The following is a description of a gene set: studied in species Homo sapiens Genes up-regulated in arthritic (KRN model) CD4 T cells: germ free versus specific pathogen free conditions. Human Gene Set: GSE22140_GERMFREE_VS_SPF_ARTHRITIC_MOUSE_CD4_TCELL_UP from publication Wu HJ, Ivanov II, Darce J, Hattori K, Shima T, Umesaki Y, Littman DR, Benoist C, Mathis D (PMID 20620945) A general defect of GF K/BxN T cell proliferation response toward antigen motivated us to look for the impairment in GF K/BxN T cells that might leads to the low Ab production and reduced disease phenotype seen in GF K/BxN mice. To find the difference between GF and SPF K/BxN T cells in a broad and non-biased fashion, we performed gene-expression profiling of these cells using microarrays., and this is the list of marker genes: USP9Y (NCBI Gene Id 8287), ATP6AP1, CR1, BID, OASL, IGF1, DEFA4, BLZF1, LETMD1 (LETM1 domain containing 1), HOMER2, TLR5, EIF2S1, EFEMP2, HNRNPAB, APOBEC3C, CTSK, RPS6KA2, HCG4B, CTSL, CSF3R, RAB40B, NBR2, F13A1, RPL15, ERGIC3, DNAAF11, GADD45B, FSCN1, POP1 (NCBI Gene Id 23044), DNAJB9, KITLG, EREG, RERE, UBAP2L, POM121L6P, PLAU, SQSTM1, XPO6, BLVRA, FCMR, PHYH (phytanoyl-CoA 2-hydroxylase), OAS1, TRIP10, IFITM2, CD59, SERPINB2, IBTK, CXCL11, MX1, IL7R, GTF2H3, CXCL1, OLFML2B, FARP1, NCK2, TNFSF10, MAT2A, SYNJ2, MAPK13, FOXF1, PML, FBLN5, IRF9, FUT4, GABPB1, CELSR1, HESX1, PLCB4, PLD3, MMP7, ZBTB39, BCAR3, PLEK, IFIT1, GCLM, NOP56, RAP2C, DEGS1, XAF1 (XIAP associated factor 1), MRC1, MYO7A, ITSN1, IKZF1, CCNE2, MYO1E, ITGA6, AKR1C3, MAP3K1, NQO1, HTRA1, ITGB5, IFIT2, PDXDC1, NUP50, IL6, LIG4, SCAMP1, NUCB2, RGL1, ZC3HAV1, ZNF101, TSPAN4, CCT2, NUP188, RAB35, VASP, ABCE1, BEST1 (NCBI Gene Id 7439), MTSS1, PPP3CA, PCSK6, HIP1, SNCB, DMXL1, SLC7A8, ADCY3, THBS1, CXCL6 (C-X-C motif chemokine ligand 6), SEC23IP (NCBI Gene Id 11196), RTCB, PPY, PIP, IFIT5, CPQ, HS3ST1, MTFR1, MPP1, KCNC4 (potassium voltage-gated channel subfamily C member 4), TCF12, RNFT2, IFIT3, SH3GL1, CCL18, ELK3, ST3GAL6, MX2, IFI44, CD99, ATP8B3, SAR1A, CCL20, PHLDB1, S1PR1, FN1, CCNC, RSAD2, ADH5, COL15A1, PLIN2, ARNT2, TRIM27, DHX30, ELL2, CLEC11A, TUBB4A, DNASE1L1, SNRNP35 (NCBI Gene Id 11066), OAS2, GPS2, TFPI, IRF1, IPO7, CXCL10, CD4, ORC3, GPNMB (NCBI Gene Id 10457), PPBP, EPHX1, TMF1, SELENOP, WDR1, IRF7, APLP2, HPCAL1, PIBF1, IFI44L, POU2F2 (POU class 2 homeobox 2), ISG15, TPM1, CEBPZ (NCBI Gene Id 10153), SRP72, NOP16, STX4, CAPN2, MAGED1, CARM1, NISCH, PUM3 (NCBI Gene Id 9933), NRP1, PIM2, CCL15, EZH2, CLIP2 (CAP-Gly domain containing linker protein 2), FERMT2, AIMP2, DNMBP, RAB5C, ADD1, TACC1, CCL8